Given this list of marker genes Upf1, Rnps1, Smg9, Secisbp2, Nbas, Ncbp1, Pym1, Skic2, Gspt1, Pnrc2, Parn, Rc3h1, Eif4a3l1, A1cf, Smg8, Eif4a3, Ctif, Exosc10, Hnrnpab, Smg5, Casc3, Syncrip, Rbm8a2, Skic3, Eif3e, Apobec1, Upf3b, Upf2, Dcp1b, Ncbp2, Gspt2, Smg6, Dhx34, Upf3a, Zc3h12a, Pnldc1, Smg7 (NCBI Gene Id 226517), Pabpc1, Smg1, Etf1, Magoh, Pnrc1, Dcp2, Rbm8a, Dcp1a, Skic8, Magohb, Eif4a3l2, here is a description of the gene set: Mouse Gene Set: GOBP_NUCLEAR_TRANSCRIBED_MRNA_CATABOLIC_PROCESS_NONSENSE_MEDIATED_DECAY The nonsense-mediated decay pathway for nuclear-transcribed mRNAs degrades mRNAs in which an amino-acid codon has changed to a nonsense codon; this prevents the translation of such mRNAs into truncated, and potentially harmful, proteins. studied in species Mus musculus